Given this list of marker genes F2RL1, MORF4L2, OAS1, RAP1GAP, ODC1, FEZ1, EFHD2, NIBAN1, CABLES1, CABYR, ALDH1A1, CD44, AHNAK, RGCC, UGT1A7, CTSB, PPP1CB, SLC14A1, CYP1A2, AZIN1, NDRG4, KYNU, AADAC, MT1A, ANXA2, TGIF1, ALDH1A3, SPTSSA, MFSD1 (major facilitator superfamily domain containing 1), EEIG1, ABLIM1, ASS1, GCLC, ADGRF1, ARL14, KLHL5, SLC16A5, APOBEC3B, CIRBP (NCBI Gene Id 1153), SLC7A2, SMIM14, ALDH3A1, SMAD3 (NCBI Gene Id 51521), TRIM31, TNFRSF21, SLC2A10, PLPP3, GK, CHMP1B, SDCBP2, SOD2, CYP3A5 (NCBI Gene Id 1577), CCDC28A, TXNRD1, AP1S2, RNF141, ABHD3, LAMP3, RNF145, B4GALT4, SLC7A11, MT1X, CACNA2D3, SPP1, ABHD2, AKR1C4, RASL11B, PIR, THBS1, GSDME, ABCC5, KLF6, EMP1, MMP7, DHRS9, SRSF7, PTGES, DPYSL2, AKR1B10, NQO1, HSPA8, CEACAM6, AGPAT2, WIPI2, GLS (NCBI Gene Id 51679), CEMIP, NSD3, TMEM163, PGD, ANKRD10, EGLN3, TXNIP, WNT5A, FYB1, MALL, ANXA10, S100A9, ACOT4, ATP2A2, SAMD9, IL7R (NCBI Gene Id 3575), PANX2, ICA1, PTGR1 (NCBI Gene Id 22949), ALDH3B2, SLC40A1, CCPG1, WDR55, CYP1B1, SPOCD1, PLEC, SRXN1, TMEM106B, SPRR1A, TXN, ANXA1, IFNGR2, AGR3, MLPH, SLC23A3, SPRR3, LCN2, IGFBP3, GPAT3, CYP4F11, SERPINB8, APOL2, ZBTB7C, PGM3, KRT23, LXN, FSCN1, LYPD3, HAS3, FTH1, PARP4, UGDH, FBXO32, FTL, AKR1B15, PCDH7, CTXN1, ANXA8, RAB27B, LAMB3, ZG16B, UBE2Q2, HSPA1A, BABAM2, SHISA2, MX1, LAMC2 (laminin subunit gamma 2), HSPA1B, BEX2, SERPINE1, ST3GAL1, OLR1, ALDH3A2, C17orf58, JAK1, HMGCS2, RAB22A, CRIP2, HMOX1, WARS1, DEFB1, PRSS1, PIM1, KLF13, CBR3, here is a description of the gene set: Genes up-regulated in transformed spheres compared to blebbishields from RT4 cells Apoptosis is a process that kills cells. However, cancer stem cells find ways to escape death after commencement of apoptosis. One such mechanism is blebbishield emergency program, in which the apoptotic cancer stem cells first undergo apoptotic body formation but then reassemble apoptotic bodies with main body (nuclei containing) of the apoptotic cells to form spherical to elongated structures called blebbishields. Blebbishields in turn are capable of blebbishield-blebbishield fusion to form transformed stem cell spheres (transformation phase) and then give rise to individual cancer cells from spheres (exit phase). We identified blebbishield emergency program in RT4 bladder cancer cells (RT4P=P stands for parental) and did microarray analysis of live RT4P cells, blebbishields and transformed spheres. This data set is a comparison of blebbishields with transformed spheres and the gene list includes the genes that are upregulated in transformed spheres. A separate set is provided for downregulated gene list too. In addition we provide separate gene lists for upregulated and downregulated gene lists for blebbishields compared to RT4 live cells. species: Homo sapiens Human Gene Set: JINESH_BLEBBISHIELD_TRANSFORMED_STEM_CELL_SPHERES_UP from publication Jinesh GG, Kamat AM (PMID 28855211)